Given this list of marker genes MMS19, ERCC2, CIAO1, CIAO2B, SLC25A5, here is a description of the gene set: Human Gene Set: GOCC_MMXD_COMPLEX species: Homo sapiens A protein complex that contains the proteins MMS19, MIP18 and XPD, localizes to mitotic spindle during mitosis, and is required for proper chromosome segregation.